The following is a description of a gene set: The process that results in the uptake of a G protein-coupled receptor into an endocytic vesicle. Mouse Gene Set: GOBP_G_PROTEIN_COUPLED_RECEPTOR_INTERNALIZATION studied in species Mus musculus, and this is the list of marker genes: Dnm2, Grk4, Arrb2, Apln, Arrb1, Necab2, Pld2, Ptger3, App, Ubqln2 (NCBI Gene Id 54609), Adm, Arr3, Apela, Dnm1, Aplnr, Sag, Drd3, Drd2